The following is a description of a gene set: Human Gene Set: HP_SOFT_DOUGHY_SKIN A skin texture that is unusually soft (and may feel silky), and has a malleable consistency resembling that of dough. species: Homo sapiens Soft, doughy skin, and this is the list of marker genes: MGP, XYLT1, SLC2A10, ADAMTS2 (NCBI Gene Id 9509), B3GALT6, COL5A1, COL5A2, COL1A1, IARS1, COL1A2, INPPL1, SON, MICU1, AEBP1